Given this list of marker genes USE1 (unconventional SNARE in the ER 1), RCN3, TTC13, ZNRF1, LIG1, RPS6KB1, RPL36, SHMT2, RPS9, RPL36A, CKS2, BOLA2, TMSB10, PSME2, CCT2, RGS10, TIMM10, SP2, EYA2, BICDL1, MAGOHB, TRAF1, RPL29, RUVBL1, RPLP0, CXCR3, CCDC62, RPL37A, RPSA, GPR183, ITGAX, RAB21, CALHM6, RPS2, TBC1D19, ARL6IP4, FOXO1, LY6E, LYST, PDLIM2, TCF7, NSA2, RPL23, CD27, RCSD1, STBD1, IMPDH2, QTRT1, GAS5, ACTN1, ZC3H12D, KLK8, EOMES, SUGP1, SATB1, TENT5A, NOP53, GRAP, NEFH, PARP2 (poly(ADP-ribose) polymerase 2), PKP4, NOP58, POLR1G, MPC2, RPL30, ME2, PDK1, HSD17B8, RPL8, MGAT2, RFX7, RPS3, MRPL23, RPS8, BCAS3, KBTBD11, PIP4K2A, RPL14, HOOK1, CAPN11, IKBKB, LTB, EIF2S1, SPRYD4, HSH2D, PUSL1, RPL4, RETREG1, RBM8A, CCT5, NDUFB9, RPL22, DUSP6, EIF3F, EEF1B2, DGKA, DKC1 (NCBI Gene Id 1736), PHF12, PLAC8, HSD17B10, RPS20, COX19, RARS2, RPL3, IKBKE, RAD50, PGLYRP1, DAPL1, AGA, RRAS2, MPC1, SIDT1 (SID1 transmembrane family member 1), LTV1, SRF, PDE2A, CLTA, DPP4, IMMP1L, METTL27, GPHN, CLEC2D, H4C16, NOP16, CHD3, ATP5MC1, COPS5 (COP9 signalosome subunit 5), RPL39 (ribosomal protein L39), TNFSF8, SNRPE (NCBI Gene Id 6635), NIFK, SHISA5, CD3D, BATF, VIPR1, RPL5, TRIM21, MED21, NSG2, RPS12, MBOAT1, CIAO2A, PSMB8, GMFG, RPL23A, RBM25, RNF138, IL7R, PPP3CC, F2RL1, RPS19, TFAM, RPL27, RPL12, ZSCAN12, RPL32, FCHSD2, SLAMF6, SAMHD1, RPS10, GSTP1, MED12, RTP4, RPL18, ATP5F1C (NCBI Gene Id 511), RPL37, NDUFB7, CD72, here is a description of the gene set: The two major human gd T cell subsets, Vd1 and Vd2, display differences in tissue tropism and agonist responses, but we have little insight into global differences that may exist at the gene expression level. This is due to the small numbers of these cells that can be obtained from healthy donors, which limit comprehensive, comparative gene expression analyses. We established a culture method that expands Vd1 and Vd2 cells from the same PBL preparation to levels sufficient for sorting and microarray analysis. Although the subsets were expanded identically (anti-TCR mAb, plus IL-15), 392 and genes were identified, which were differentially expressed in the two subsets, from two donors, respectively. Approximately genes changed in both subsets following PMA/ionomycin treatment; about 50% of these genes were subset-specific. Both subsets responded to a crude LPS preparation, but only 6% of the responsive genes were the same. The differentially expressed genes were consistent with Vd2 cells being more inflammatory and Vd1 cells having more of a regulatory phenotype. Both subsets expressed transcripts encoding an array of innate and NK cell receptors, supporting the relationship of gd T cells to the innate immune system. Our results show that circulating Vd1 and Vd2 subsets in humans have considerable, inherent differences in gene expression following treatment with non-TCR agonists, supporting unique functional roles for these cells in vivo. from publication Kress E, Hedges JF, Jutila MA (PMID 16423401) species: Homo sapiens Genes up-regulated in Vd2 gamma delta T cells: untreated versus LPS. Human Gene Set: GSE3720_UNSTIM_VS_LPS_STIM_VD2_GAMMADELTA_TCELL_UP